Given this list of marker genes IQSEC2 (NCBI Gene Id 4382), NCF1, ATP6V0A2, TRPM4, B3GAT3, WNT10A, BRF1, TBC1D24, EDA2R, VPS37D, PARN, BBS1, ADAMTS10, RHOA, MAPK8IP3, BBS4, ATP6V1B2, DLX3, NEK1, CACNA1I, ST14, TERC (NCBI Gene Id 7012), UBR1, GJA1, CTCF, PDGFRA, ADAMTS3, ASCC3, PEX6, C1R, CKAP2L, ORC1, DKC1, CDK13, DHX37, EYA1, SMOC2, OCRL, RFC2, PIGL, BUD23, SNRPN, DLG1 (NCBI Gene Id 1739), TBL2, LONP1, IFIH1, TNFRSF11A, VPS51, BBS2, TMEM270, NOP10, HRAS, NMNAT1, C1S, KIAA0753, NHP2, PRIM1, RPS6KA3, PCGF2, PYCR1, FOXC1, SOX9, KCNK9 (NCBI Gene Id 51305), CLCN7, CTNND1, MED12, DPH2, CSTB, PQBP1, IFT122, WHRN, WDR4, NELFA, GLI1, GTF2IRD2, ZNF141, SATB2, KAT6B, DNAJC30, BBS7, WDR19, SMARCAL1, FBN1, PLXNA1, KRAS, FGF3, EVC2, ANTXR2 (ANTXR cell adhesion molecule 2), GALNT3, KRT71, NECTIN4, EDARADD, WNT10B, SMARCA2, STX1A, BMP4, RIN2, AAGAB, PLEKHM1, SCAPER, LRP6, TGFA, DPF2, CHSY1, IFT74, MBD5, LETM1, IFT27, MKKS, ARHGEF38, COBLL1, FGFR2, B3GALT6, KMT2D, H4C5, MAPRE2, FAM20C, DEAF1, RUSC2, COL3A1, FARS2, B3GLCT, GHR, ADGRV1, NSD2, REV3L, CEP19, TFAP2A, SATB1, GTF2I, CTBP1, EDA, GRIA3, NECTIN1, TSPEAR, IFT43, CDK10, CDH3, CNTNAP2, RECQL4, PCNT, GJB2, ARL6, GJA5, PURA, GTF2IRD1 (GTF2I repeat domain containing 1), RTEL1 (NCBI Gene Id 53593), MAPK1, AXIN2, NAA80, SMOC1, FBXO28, PPP1R13L (protein phosphatase 1 regulatory subunit 13 like), ARID1B, MYO7A (myosin VIIA), TCF12, TTC8, RAI1, GRB10, EIF4H, FGFR3, IDS, SH3BP2, NHS, KAT6A, EVC, BBS9, PIGG, ZFX (zinc finger protein X-linked), BRCA1 (BRCA1 DNA repair associated), KDF1, NRAS, PIK3R1, PIGF, MLXIPL, TINF2, METTL27, ARHGAP29, CHD3, IKBKG, IRF6, PAX9, TCIRG1, WRAP53, CREBBP, SUMO1, KANSL1, BCOR, POLR1D, ANAPC1 (NCBI Gene Id 64682), HEPHL1, PLXND1 (plexin D1), VPS13B, POLR1C, IFT52, BCL11B, CCDC47, KRT14, BBIP1, POLR1B, GREM2, ENAM, WDR35, BBS5, SMARCD2, NPM1, CTC1 (NCBI Gene Id 80169), EDAR, CDH1, WDPCP, SMC3, NFIX, PIGA, FLII, COL11A1, TRPS1, PRKD1, FKBP6, DHCR7, SRCAP, TONSL, DLX4, IFT172, RIC1, GJA8, CLIP2 (NCBI Gene Id 84805), ALX4, TMCO1, MCOLN1, PKP1, BRD4, RBBP8, DHODH (NCBI Gene Id 1723), ATR, KCNMA1, FGFR1, TWIST2, MSX1, NPHP1, USB1, SCLT1, P4HB, SIX1, BBS10, PORCN, PRKACA, DCHS1, HS2ST1, FAT4, LMBRD2, SLC25A24, BBS12, CFAP418, BAZ1B, ELN (NCBI Gene Id 2006), CDH11, TP63, SCNM1, KDM6A, MKS1, PDZD7, CPLX1, TRIM32, LAMB3, TRAF6, CACNA1C, FGF10, PACS2, ADNP, LZTFL1, SLC35A2, CHST3, LIMK1, DNAJC21, PIK3C2A, TCOF1, DYNC2LI1, LTBP3, USH2A, TYMS (thymidylate synthetase), RNU12, PRKACB, SEC23A, SDCCAG8, ABCC9, PEX1, ZEB2, IFT140, IDUA, UBE3B, CEP290, ANKRD11, MGAT2, PITX2, CCBE1, NFKBIA, NAA10, EP300, RMRP, TERT, here is a description of the gene set: species: Homo sapiens Abnormal dental morphology An abnormality of the morphology of the tooth. Human Gene Set: HP_ABNORMAL_DENTAL_MORPHOLOGY